Given this list of marker genes ARID4A, NUFIP2, ASXL2, EPHB1, STK35, PIM1, ARHGAP11A, DNMT1, MCM8, PHF5A, SPTB (NCBI Gene Id 6710), TYRO3, ZNF503, SLCO3A1, SUV39H1, RRM2 (NCBI Gene Id 6241), RET, IER5L, GMNN, KCNS2, CCNT1, PCNA, HIRA (histone cell cycle regulator), RAVER1, ZNF524, KBTBD6, FANCD2, TMEM143, EZH2, SLC9A5, ATAD5, NASP, UNG, MXD3, PTMA, HMGXB4, SLITRK4, DCK, WBP2NL, BRPF1, ILF3-DT, MCM3, SRSF7, IL4I1 (interleukin 4 induced 1), SLC9A7, TFAP4, ZCCHC8 (NCBI Gene Id 55596), HNRNPUL1, HNRNPD, CDC25A, ARHGAP6, AP4M1, ILF3, RANBP1, OTUD7B, TRMT6, AK2, POLD1, ZNF367 (NCBI Gene Id 195828), PBRM1, SMC3, BRMS1L, CBX3, H2AZ1, ZCWPW1, CDC20B, EMC3, GRIA4, SMC1A, EFNA5, MCM7, PEG3 (paternally expressed 3), SPINK5 (NCBI Gene Id 50962), H2BC12, CDCA7, KCNA6, DNAJC9, SMAD6, TOPBP1, PCLAF, GON7, SMC6, ZNF644, MCM2, UBR7, EIF4A1, E2F8, TBX6, HNRNPA2B1, GAPDH, ADAMTS2, TRMT2A, PAX6, ACO2, MAZ, E2F7, SRSF1, PCIF1, MAPK6, H2AZ2, APPL1, MAPT (microtubule associated protein tau), MSH5, GSPT1, MYH10, NRK, TRIM39, JADE1, NR6A1, HS6ST3, GEN1, MSH2, FHOD1, CDC5L, VCAN, NUP62, PAN2, KBTBD7, TAOK2, HOXC10, WDR62, SOAT1, NFATC2IP, PRP4K, PPIG (NCBI Gene Id 9360), FBXO5, ACBD6, ATF5, CDC6, CASP8AP2, ZNF687, KMT5A, DMD, TMPO, PRPS2, TRMT13, SUMO1, CDK1, RBL1, FMO4, TMEM108, PAQR4, POU4F1, THAP8, DCTPP1, CORT, TLE3, POLD3, USP37, TRA2B, RIBC1, NCL, POLR1G, JADE2, PODN, CLSPN, ZIM2, MCM6, NOLC1, E2F3, NABP2, MYC, DNAJC5G, PLAGL1 (PLAG1 like zinc finger 1), PKMYT1, RPS20, E2F1, HMGA1, H3C1, STT3B, POLA1, DLG3, MCM4, GATA1, ALDH6A1, FKBP5, HNRNPR, YTHDC1, POLE4, GINS3, YBX2, GLRA3, ZBTB4, MRPL40, KIAA0825, SEMA6A, GPRC5B, MEPCE, MAP3K7, AP1S1, SYNGR4, RASAL2, TMEM187, IPO7, POLE2, ZNF362, EHBP1, LUC7L3 (NCBI Gene Id 51747), RPS6KA5, MTF2, MCMBP, STMN1, RMI2 (RecQ mediated genome instability 2), NIPBL, EMSY, POLR2A, FIZ1, HCN3, CNOT9, GPBP1, RTBDN (NCBI Gene Id 83546), STAG1, H4C1, NELL2, CAND1, SASS6, SNRPD1, ID3, PHC1, CTDSPL2, BRME1, APH1A, SP3, GABRB3, PCSK1, SYNCRIP, PRPS1, FANCG, KANSL3 (NCBI Gene Id 55683), ING3, ZNF565, H2AC12, PPM1D, ATAD2, FANCC, EED, UGGT1, PRKDC, here is a description of the gene set: species: Homo sapiens Human Gene Set: E2F1DP1_01 Genes having at least one occurrence of the motif TTTCSCGC in the regions spanning 4 kb centered on their transcription starting sites. This matches the E2F1, TFDP1 transcription factor binding site V$E2F1DP1_01 (v7.4 TRANSFAC).